The following is a description of a gene set: studied in species Mus musculus Mouse Gene Set: GOMF_CALCIUM_DEPENDENT_PROTEIN_SERINE_THREONINE_PHOSPHATASE_REGULATOR_ACTIVITY Binds to and modulates of the activity of the enzyme calcium-dependent protein serine/threonine phosphatase., and this is the list of marker genes: Ppp3r1, Rcan3, Ppp3r2, Rcan2, Rcan1